Given this list of marker genes Drd2, Ppp1r9a, Dmpk, Chrna7, Ctnna2, Ncan, Camk1, Cdc42, Shank3, Frmpd4, here is a description of the gene set: Mouse Gene Set: GOBP_REGULATION_OF_SYNAPSE_STRUCTURAL_PLASTICITY Any process that modulates the frequency, rate or extent of synapse structural plasticity. Synapse structural plasticity is a type of cytoskeletal remodeling; this remodeling is induced by stimuli that can lead to long term potentiation and it can be activity-dependent or -independent. Examples of cytoskeletal changes include the formation of new spines and increase in spine size; this can be accompanied by the insertion of greater numbers of glutamate (or other neurotransmitter) receptors into the post-synaptic membrane. studied in species Mus musculus